The following is a description of a gene set: species: Homo sapiens Human Gene Set: GOCC_CTF18_RFC_LIKE_COMPLEX A heptameric complex related to replication factor C, which loads the DNA polymerase processivity factor proliferating cell nuclear antigen (PCNA) onto DNA and plays a vital role in chromosome cohesion. In Saccharomyces the subunits are known as Ctf18p, Rfc2p, Rfc3p, Rfc4p, Rfc5p, Dcc1p, and Ctf8p., and this is the list of marker genes: RFC2, DSCC1, CHTF8, CHTF18, RFC3, RFC5, RFC4